Given this list of marker genes MIR9-1, HAMP, SLC15A2, SLC8A1, FXYD5, SLC22A5, KCNK18, KCNIP2, MIR21, MIR133B, KCNQ1, MIR1-1, CALM3, ATP12A, CALM2, KCNE3, ATP1A3, ATP2B3, KCNE2, FXYD6P3, MIR133A1, KCNA5, MIR873, SLC24A4, YWHAE, RALBP1, ABCG1, MIR185, ABCC5, SLC30A10, KCNIP1, SLC22A2, SLC30A4, MIR186, SLC17A3, MIR508, ANO6, KCNK5, CALM1 (NCBI Gene Id 801), KCNE4, NEDD4, ABCC4, ATP4B, SLC22A18, SLC40A1, KCND3, RGS9, NPPA, ATP2B1, ATP7B, FXYD2, MIR129-1, KCNB1, FXYD7, OSCP1, SLC9A1, KCNH2, ABCG2, FXYD6, SLC8A3, ATP1A4, ATP1A2, MIR495, ATP1B1, ABCB1, FXYD1, KCNE1, SLC8A2, PDZK1, ABCA1, WWP2, MIR451A, ATP4A, SLC47A1, KCNT2, MIR34B, SLC35G1, SLC47A2, SLC4A4, FXYD3, SLC29A4, FXYD4, KCNA2, NEDD4L, ATP1B2, SLC30A1 (solute carrier family 30 member 1), TMEM163, GJA1, ATP1A1, ATP1B3, ABCC1, SLC38A5, HEPH, MIR326, WNK4, SLC27A1, SLC30A2, DLG1, KCNE5, here is a description of the gene set: Human Gene Set: GOBP_EXPORT_ACROSS_PLASMA_MEMBRANE The directed movement of some substance from inside of a cell, across the plasma membrane and into the extracellular region. studied in species Homo sapiens